Given this list of marker genes SMC3, PIGQ, AP1G1, PRR12, SOX6, RNU4-2, MYMX, CDC42BPB, here is a description of the gene set: studied in species Homo sapiens Eyelid partly covered by skin when eyes are open. Human Gene Set: HP_HOODED_EYELID Hooded eyelid